Given this list of marker genes WDR5, MYO19, PRND, PTPRO, MORF4L2, RAD51AP1, BUB3, PRPF19, FANCL, MYO1E, FITM1, CDH6, OAT, PRPF31, FPR2, RRM2, NUDC, CYP11B2, HDAC3, ADORA2B, KYAT3, CD48, TPRG1, SUCLG2, KRT35, SUV39H1, TRIB1, UCK2, TNF, TIMM8A, C5AR1, SGO2, FUT4, CGAS, CHTF8, ANKRD52, ALOX15, EXOSC2, WASHC2A, DARS1, PBK (NCBI Gene Id 55886), MRPL50, ANKRD13B, PLEK, DSE, CFDP1, SLC4A3, CENPC, NARS2, MAP3K20 (mitogen-activated protein kinase kinase kinase 20), TMEM239, CD96, CMTR2, KIF20A, FUS, CDC45, ABCB8, GPSM1, SLC22A15, UBE2N, CNOT10, ETF1, H2AZ1, DIS3, ARMCX4, APLP2, IFNGR1, NUP37, HINT1, TNFAIP2, GFM1, ATAD2, RBBP7, CLEC5A, WDR46, DDX39B, TOP1MT, SYPL1, SPATA24, MEI1, TOP2B, PDE6H, RPP40, EEF1E1 (NCBI Gene Id 9521), IRF6, ADAM17, UHRF1, USP14, TBXAS1, TCP1, SHQ1, OSGEP, PSMG2, PA2G4, NDUFAF2, MLH1, YWHAQ, ABRACL, NAP1L1, RRS1, PHTF2, DHFR (NCBI Gene Id 203373), FASN (NCBI Gene Id 2194), MYO3A, ACTL6A, CCNH, UBTD2, SLC16A1, HSPBP1, SNRNP40 (NCBI Gene Id 9410), TXNDC5, RRP15, G3BP1, NPM3, ATIC, HSD17B7, MTHFD1, PPA2, WLS, HPRT1, LHX4, TPGS2, JPT2, ABCG2, KCNK7, LARP7, EIF3G, UBE2T, RWDD4, ESCO2, PPIL3, DTWD1, MRPS26, GLO1, LYPD3, DHX9, ATAD5, LTV1, ECT2, NFATC2, SMOC1, UTP18, MPP3, NPPA, ELMO1, SLC35A4, ANKRD10, LSM6, NOC3L, POLE4, ADAMTS1, TIPIN, OSTC, PRC1 (protein regulator of cytokinesis 1), LBR (NCBI Gene Id 653311), UBE2E3, SNHG7, ALDH3A1, MANF, BCAP29, FAM124B, RANBP1, NAT10, P4HB, FAM43A, SLC25A17, NNT, CCNA2, YEATS4, CTPS1, DEPTOR, TMX4 (NCBI Gene Id 56255), NOP2, TNFRSF17, MRPL20, PCSK6, CXCL3, RPN1, SLC12A6, SET, NCKIPSD, GATA3, SRSF10, GLE1, FRMD3, SEC61A1, SLC12A2, FAM217B, SREBF2, POLD2, KNTC1, KIF23, EMB, CACNG4, ARHGDIB, FYTTD1, GSAP, BAMBI, PRIM2, here is a description of the gene set: Human Gene Set: GSE22432_CDC_VS_COMMON_DC_PROGENITOR_DN Dendritic cells (DCs) in lymphoid tissue comprise conventional DCs (cDCs) and plasmacytoid DCs (pDCs) that develop from common DC progenitors (CDPs). CDPs are Flt3+c-kitintM-CSFR+ and reside in bone marrow. Here we describe a two-step culture system that recapitulates DC development from c-kithiFlt3-/lo multipotent progenitors (MPPs) into CDPs and further into cDC and pDC subsets. MPPs and CDPs are amplified in vitro with Flt3 ligand, stem cell factor, hyper-IL-6 and insulin- like growth factor-1. The four-factor cocktail readily induces self-renewal of MPPs and their progression into CDPs and has no self-renewal activity on CDPs. The amplified CDPs respond to all known DC poietins and generate all lymphoid tissue DCs in vivo and in vitro. Additionally, in vitro CDPs recapitulate the cell surface marker and gene expression profile of in vivo CDPs and possess a DC-primed transcription profile. Transforming growth factor-β1 (TGF-β1) impacts on CDPs and directs their differentiation towards cDCs. Genome-wide gene expression profiling of TGF-β1-induced genes identified transcription factors, such as interferon regulatory factor-4 (IRF-4) and RelB, that are implicated as instructive factors for cDC subset specification. TGF-β1 also induced the transcription factor inhibitor of differentiation/DNA binding 2 (Id2) that suppresses pDC development. Thus, TGF-β1 directs CDP differentiation into cDC by inducing both cDC instructive factors and pDC inhibitory factors. from publication Felker P, Seré K, Lin Q, Becker C, Hristov M, Hieronymus T, Zenke M (PMID 20881193) studied in species Homo sapiens Genes down-regulated in common dendritic cells versus those cultured and untreated.